The following is a description of a gene set: from publication Chen Y, Wang X (PMID 31504780) Human Gene Set: MIR6810_5P Genes predicted to be targets of miRBase v22 microRNA hsa-miR-6810-5p in miRDB v6.0 with MirTarget v4 prediction scores > 80 (high confidence targets). species: Homo sapiens, and this is the list of marker genes: FIGNL2, ZHX3, KCTD15, ZNF337, TRMT13, ZNF219, CHUK, SEMA5A, KRTAP13-1, PPP1R9B, CREM, MORC2, CAMKK1, FOXM1, ESRRG, LYPLA2, PLEKHS1, NETO1, TPSD1, CLIP3, CLDN2, BCAM, SHISAL1, TRAK1, PDE8B, MRAP2, HECTD3, PHKA2, FGFR1, RTL4, NLRC3, SOX13, CELF4, ADAM23, TTLL5, SMARCC2, CASP10, CRIPTO, NHLRC4, KSR2, SIDT1, DDN (dendrin), ELK1, CAPN5, HNRNPA2B1, ZNF207, SLC6A9, RPEL1, IQCK, BNC2, TAF10, DCHS1, SLC1A5, FGFR2 (fibroblast growth factor receptor 2), ITPR2, PIP5K1C, ZNF41, CSNK1A1, IP6K2 (NCBI Gene Id 51447, inositol hexakisphosphate kinase 2), TRARG1, GNG7, TAB3, ZFTA, SLC38A2, RIBC1, VAT1, COMMD9, DCX, ELAVL3, IFNLR1, TRAM1, GNAO1